Given this list of marker genes Ube2b, Ooep, Rad51ap1, Msx1, Npr2, Camk2b, Prdm9, Wnt5a, Piwil2, Dmrt1, Wnt4, Sirt2, Eif4g3, Meiosin, Msx2, Stra8, Plcb1, Gja1, Dazl, Fbxo5, Npm2, here is a description of the gene set: Any process that activates or increases the frequency, rate or extent of meiosis. Mouse Gene Set: GOBP_POSITIVE_REGULATION_OF_MEIOTIC_NUCLEAR_DIVISION studied in species Mus musculus